The following is a description of a gene set: Reactome Pathway: Separation of Sister Chromatids While sister chromatids resolve in prometaphase, separating along chromosomal arms, the cohesion of sister centromeres persists until anaphase. At the anaphase onset, the anaphase promoting complex/cyclosome (APC/C) ubiquitinates PTTG1 (securin), targeting it for degradation. PTTG1 acts as an inhibitor of ESPL1 (known as separin i.e. separase). Hence, PTTG1 removal initiated by APC/C, enables ESPL1 to become catalytically active. ESPL1 undergoes autoleavage and also cleaves RAD21 subunit of centromeric cohesin. RAD21 cleavage promotes dissociation of cohesin complexes from sister centromeres, leading to separation of sister chromatids. Subsequent movement of sister chromatids to opposite poles of the mitotic spindle segregates replicated chromosomes to two daughter cells. part of: Mitotic Anaphase studied in species Homo sapiens, and this is the list of marker genes: RANBP2, UBC, NDE1, TUBB8B, PSMC1, CDC26, PSMB4, SPC25, SGO2, SEH1L, RCC2, TUBB2A, ANAPC5, SEM1, NUDC, PSMA1, UBE2C, PSMD13, PSMD8, PPP2CA, ZWILCH, PSMA2, ERCC6L, PSMD11, PSMA5, TUBA4B, CENPQ, TUBB4A (tubulin beta 4A class IVa), PSMD7, TUBB2B, ANAPC4, RAD21, CDCA8, TUBB8, DYNC1LI2 (NCBI Gene Id 1783), KNTC1, PSMB7, CENPE, ANAPC16, PPP2CB, SGO1, CDC23, TUBB3, ITGB3BP, NUF2, RPS27, HDAC8, PMF1 (polyamine modulated factor 1), DYNC1H1, KIF18A, CENPM, TUBA8, CENPC, BUB1B, KIF2B, RANGAP1, STAG2, PSMD2, TUBAL3, B9D2, PSMA4, DYNC1I1, PSMB3, DYNC1I2, SKA2, ADRM1, CLASP2, PPP2R1A, PPP2R5C, INCENP, AHCTF1, PPP2R5D, TUBA3C, TUBA3D, CDCA5, NUP160, DYNC1LI1, PSMA6, NUP133, PPP2R1B, PPP1CC, UBA52, TUBA1B, NUP98, PSMD6, PPP2R5B, CLIP1, ANAPC7 (anaphase promoting complex subunit 7), UBE2S, RPS27A, TUBA3E (tubulin alpha 3e), UBE2E1, SMC1A, NUP107, CDC20, CKAP5, MAD1L1, NSL1, CENPA, CDC16, MAD2L1, SPDL1, NDC80, PSMB1, KNL1, TUBA4A, PSMB6, PPP2R5A, CENPU, ZW10, PSMD14, TUBA1A, TUBB4B, PSMC4, CENPN, TUBA1C, TUBB1, CENPH, CENPS (centromere protein S), SPC24, ANAPC2 (anaphase promoting complex subunit 2), BUB3, DYNLL1, PSMD12, CENPP, PPP2R5E, TUBB6, CENPF, UBB, CLASP1, KIF2C, CENPL, MIS12, DYNLL2, PSMC3 (proteasome 26S subunit, ATPase 3), NUP85, PSMC5, PSMB5, CENPT, SKA1, CENPK, MAPRE1, NUP43, ZWINT, NDEL1, CENPO, PDS5A, CENPI, WAPL, SMC3, PSMB2, PDS5B, KIF2A, XPO1, PSMD1, ANAPC1 (anaphase promoting complex subunit 1), ANAPC10 (NCBI Gene Id 25866), STAG1, PSMA7, DSN1, ANAPC15, CDC27, SEC13, BIRC5, UBE2D1, PSMA3, PAFAH1B1, BUB1, NUP37 (nucleoporin 37), AURKB, ANAPC11 (anaphase promoting complex subunit 11), PSMC2, TAOK1, PTTG1, PSMC6, ESPL1, PLK1, PSMD3